Given this list of marker genes PRL, PTPRCAP, B4GALNT2, VPS53, LPCAT1, CX3CR1, AP1G2, HNRNPU, GDI1, GLUD1 (glutamate dehydrogenase 1), TMED7, YBX2, TSPYL1, CRYL1, ADGRD1, SEMA6C, C22orf39, CALCOCO2, ACO1, KCNB1, TET1, ILF3, SLC2A4, OTUD7B, SAMD10, SLC25A15, UBQLN1, ERF (NCBI Gene Id 2077), ZNF638, WNT5B, NICN1, HSD17B3, ESRP2, FAM83H, SYT3, DNAJC3, PIK3CD, FGFR3, TNFSF4, ARG2, AATK, ACADVL, GCSAM, RCBTB1, TRIO, HDAC1, PLCG2, CSF3R, STAU1, C16orf89, TRAF3IP2, CIT, EFNA4, ATF2, GNA15, TIAM2, KRT71, GAPDH, SLCO3A1, DSC1, POP4, BCL2L1, MSX2, MMS19, CD2, SYT8, ADGRA3, RBP2, EEF1A2, SLC10A2 (solute carrier family 10 member 2), BDKRB2, DAB1, UHRF1, GOSR2, NOP2, KIF23, PER2, SLC25A44, ATP2A3, ETV4, PALM, E2F8, LTBP2, GOLGA4, EPHB2, TMEM30B, SLC66A3, DACH1, CD22, DLX1, COMMD9, PTGIR, TTF1, SSTR3, HTATSF1, HOXA2, TASOR, LDHB, SEC24C, P2RY1, EPHB3, RPGR, TMEM106C, FGF1, RAX, ADGRE1, PLPPR2, HLA-DOA, RAB33A, DCC, FGF9, ACP3, LBR, ATP5PB, INTS8, PARP8, CCL17, RGS3, COL12A1, NMT2, DNASE1L2, ARHGDIB, TSSC4, STX1B, LINC00612, SEC31A, MERTK, CPLX2, BIRC3, HLA-DRB1, RGCC, GUCD1, SLC33A1, KCMF1, HRK, LCT, SART1, CSF2RA (NCBI Gene Id 8282), TTC7B, ZNF18, SOX13, NREP, ATF6B, GHRH, CD38, NPTX2, PBX2, RARG, USO1, TFEB, PKP3, AHI1, HOXD1, UGT2B10 (UDP glucuronosyltransferase family 2 member B10), FSHR, DHX40 (NCBI Gene Id 79665), SH3PXD2A, AIRE, PTPRA, NFKB2, USP9X, TSC22D3, EPHA8, FLT3LG, C19orf48P, ADGRL1 (NCBI Gene Id 79732), SLC10A3, FKBP4, PDE8A, PBX3, PDE1C, SGO1, FAM118B, PDE4DIP, YJU2B, ASH2L, MRPL49, SCX, TCF12, GNB4 (NCBI Gene Id 59345), PTPN18, L1CAM, CDH16, LENG8, GSG1, SMR3A, LGALS7, SUPV3L1 (NCBI Gene Id 6832), POLE2, GGCX, ONECUT1, IL2RB, MCUR1, UROS, NBEAL2, SCMH1, HPCA, PDE6G, NOLC1, CBR3, here is a description of the gene set: Expression profiling of Rag2-deficient Ets1++ and Rag2-deficient Ets1-- mature NK cells and WT bone marrow progenitors, WT T cells, and WT Pro B cells from publication Ramirez K, Chandler KJ, Spaulding C, Zandi S, Sigvardsson M, Graves BJ, Kee BL (PMID 22608498) Genes up-regulated in multipotent progenitors versus pro-B cells. species: Homo sapiens Human Gene Set: GSE37301_MULTIPOTENT_PROGENITOR_VS_PRO_BCELL_UP